Given this list of marker genes HPRT1, SNCA, ALDH2, TACR3, SLC6A3, DRD1, CHRNB2, NPY, DRD4 (NCBI Gene Id 1815), ABAT, ITGAM, PARK7, ATP7A, PRKN, HTR1A, NR4A2, PNKD, NT5DC2, GPR37, VPS35, ITGB2, here is a description of the gene set: Any process that modulates the frequency, rate or extent of the chemical reactions and pathways involving catecholamines. species: Homo sapiens Human Gene Set: GOBP_REGULATION_OF_CATECHOLAMINE_METABOLIC_PROCESS